Given this list of marker genes DLX2, MAP3K13, LRRK2, SHOX2, FGFR2, EPHA7, BCL11A, RERE, FGF13, RTN4, DRD2, here is a description of the gene set: species: Homo sapiens Human Gene Set: GOBP_BRANCHING_MORPHOGENESIS_OF_A_NERVE The process in which the anatomical structures of branches in a nerve are generated and organized. This term refers to an anatomical structure (nerve) not a cell (neuron).